Given this list of marker genes GRM5, TSNAX, P2RY2, NECAB2, ADA2, P2RY1, USP4, here is a description of the gene set: Human Gene Set: GOMF_ADENOSINE_RECEPTOR_BINDING Binding to an adenosine receptor. species: Homo sapiens